The following is a description of a gene set: from publication Amit I, Garber M, Chevrier N, Leite AP, Donner Y, Eisenhaure T, Guttman M, Grenier JK, Li W, Zuk O, Schubert LA, Birditt B, Shay T, Goren A, Zhang X, Smith Z, Deering R, McDonald RC, Cabili M, Bernstein BE, Rinn JL, Meissner A, Root DE, Hacohen N, Regev A (PMID 19729616) mouse primary BMDCs were stimulated with tlr ligands and gene expression changes were profiled on Affymetrix arrays species: Homo sapiens Genes up-regulated in comparison of dendritic cells (DC) stimulated with poly(I:C) (TLR3 agonist) at 12 h versus those stimulated at 24 h. Human Gene Set: GSE17721_12H_VS_24H_POLYIC_BMDC_UP, and this is the list of marker genes: DSCAM, SLC35A3, CXCL2, IL6, ASB11 (ankyrin repeat and SOCS box containing 11), TCAF2, FGF19, GPM6A, DHPS, TRAF5 (NCBI Gene Id 7188), FDPS, STXBP1, GRIN2C, LXN, SVBP, GAP43, HRH2, ECI2, CIBAR1, CREB3L2 (cAMP responsive element binding protein 3 like 2), PLP2, MRPS6, TNIP1, CCDC88A, YIPF5, ATP2A1, CEMIP2, PDGFA, ANXA6, RIPK2, SMAD7, ARF5, IGSF9, CYP2J2, PPP2R2A, STAT5A, PMPCB, CAMP (cathelicidin antimicrobial peptide), CD44, PLS3, TCF4, ASNS, RMDN3, AFF1, CASK, PHLDA1 (NCBI Gene Id 22822), PDE6D, MOBP, STAM2, PDIA3, CETN3, FANK1, C1QTNF12, DDA1, SLFN13, TOX4, SRC, RSU1, TDRP, RNF4, NDST3, PRDM9, METAP1, TOB1 (transducer of ERBB2, 1), BCL9 (BCL9 transcription coactivator), IGSF6, PI4KA, FOXN2, USP18, CD302, HDC, IL1RAP, KATNBL1, ILF3, MITF, USB1, CHTF8, PLPP2, S100A9 (NCBI Gene Id 6280), SLC30A6, TFEC, AP3M2, GATM, PNPT1, CLEC5A, PAFAH1B3, PSMB6, MYO10, MET, CISH, PPP3CC, NT5C3A, PPP2R5B, NUSAP1, JARID2, KYNU, DOCK8, SPRYD7, NCK1, APPBP2, S100PBP, MCUB, PADI4, BCKDHB, PPM1B, TNFSF9, CAPG, PCSK7, SLC10A3, SLC25A22, IL12A, ST6GALNAC2, OLFM1 (olfactomedin 1), CBY2, SEH1L, GSPT1, SLC41A1, CASP1, RNF115 (NCBI Gene Id 27246), INSM1, TMEM243, DCBLD2, C11orf96, LAMTOR3, RRAGD, GADD45B, UBE2G1, APOE, TRA2B, RAB22A, SMAD2, SUB1, RAB9A, CTSC, TXNDC5, RBM3 (RNA binding motif protein 3), SAMD4B, STARD5, TNNT3, MINPP1, SEL1L, IL15RA, LSM12, COX18, IDS, SSR3, CPT1A, PSMA4, MFSD14B, RCN1, TIMP2, MORC3, ITGA6 (NCBI Gene Id 3655), LDHB, TXLNB, SFT2D2 (SFT2 domain containing 2), NDUFS8, PTGES, DUSP14, CEMIP, CYBRD1, PAPSS1 (3'-phosphoadenosine 5'-phosphosulfate synthase 1), CCDC134, CPPED1, MYL9, TTK (NCBI Gene Id 7272), TMCO3, NFKB2, NRP2, CSRP1, C3orf62, COLEC12, DEK, ANXA2, DYNLT4, ACP3, LRRC8C, PLA2G4A, TPST1, RAB20, PDZK1IP1, CD81, NKX3-2, FGF2, JPT1, SLC12A9, SPDL1 (NCBI Gene Id 54908), FRYL, HVCN1 (NCBI Gene Id 84329), ZBTB12, NR2F2, TFG, PPP2CB, TMPO, CIB2, TMED8 (transmembrane p24 trafficking protein family member 8), HADHA (NCBI Gene Id 3030), RHOB, UFM1, TNFRSF1A